Given this list of marker genes H4c14, H4c2 (H4 clustered histone 2), H4c18, H2ac23, H3c13, H3c4, H2ac10, H2ac19, H4c3, H3c10, H3c2, H4c17, Dnmt1, H4c1, H2az2, H2bc1, H2bc7, H2ac8 (H2A clustered histone 8), H2ac12, H2ac13, H2bc13, H2ac11, H3c3, H3f3a, Dnmt3b, H2ac4 (H2A clustered histone 4), H3c8, H2bc15, Ezh2, H3c7 (H3 clustered histone 7), H4c12, H2bc9 (NCBI Gene Id 319182), H2bc3, H2ac20, H4c11, H3c15, H2bc8, H4c9, H2ac22, H3c6, H2ac6, H2ac15, H2ac7, Rbbp7, H4c4, H3c1, H4c6, H2ac24, H2bc12 (NCBI Gene Id 319184), Ezh1, H2bc22, Rbbp4, H3c11, H2bc27, H2ax, H2ac1, H2bc11, H4c8, here is a description of the gene set: part of: Epigenetic regulation of gene expression This event has been computationally inferred from an event that has been demonstrated in another species.<p>The inference is based on the homology mapping from PANTHER. Briefly, reactions for which all involved PhysicalEntities (in input, output and catalyst) have a mapped orthologue/paralogue (for complexes at least 75% of components must have a mapping) are inferred to the other species. electronically inferred by orthology from the curated human pathway species: Mus musculus Reactome Pathway: PRC2 methylates histones and DNA